The following is a description of a gene set: studied in species Homo sapiens The chemical reactions and pathways involving isoprenoid compounds, isoprene (2-methylbuta-1,3-diene) or compounds containing or derived from linked isoprene (3-methyl-2-butenylene) residues. Human Gene Set: GOBP_ISOPRENOID_METABOLIC_PROCESS, and this is the list of marker genes: ALDH1A3, RDH8, PMVK, LPL, SCPEP1, SDR16C5, SRD5A1, AKR1C1, DGAT1, ABCA4, ALDH1A2, ALDH3A2, AKR1C3, HTRA2, CYP2C18, FDPS, DPM1, DHRS4L2, DHRSX (NCBI Gene Id 207063), PNLIP, PRMT3, AKR1B10, CYP2E1, LIPE, CRPPA, DGAT2, LIPA, CYP2D6, LRP8, CYP2W1, LRP1 (LDL receptor related protein 1), PDSS2, AWAT2, ADH4, HSD17B6, CYP26B1, PNPLA2, LSS (lanosterol synthase), CEL, FDFT1, IDI2, IDI1, DHDDS (NCBI Gene Id 79947), AKR1C4, CYP2C19, ADH1A, CRH, CYP1B1, CYP3A4, ADH1C, CYP27C1, PNPLA4, RPE65, UGT1A8, PLPP6, RARRES2, SRD5A3, ALDH1A1, HMGCR, UGT1A7, DHRS9, RLBP1, LRAT (NCBI Gene Id 9227), CRABP2, DHRS3, ADH5, MVD (mevalonate diphosphate decarboxylase), LDLR, AKR1B15, RDH11, DHRS4L1, RBP4, UGT1A1, PHYH, RDH10, LRP2, RBP1, BCO2, NPC2, DPM3, AKR1B1, GGPS1 (NCBI Gene Id 9453), PDSS1, CYP1A1, PLB1, COQ2, DHRS7, RETSAT, CYP2S1 (cytochrome P450 family 2 subfamily S member 1), MVK, CYP2C9, SDR9C7, CYP4V2, UGT1A3, CYP26C1, RBP2, TTR, CLPS, RDH13, CYP1A2, HMGCS2, RDH5, DOLK, CYP2C8, ADH6, NUS1, DPM2, RDH16, RDH12, UGT1A9, PECR, ALDH8A1, CYP3A7, ADH1B, RBP3, BCO1, CYP3A5, RDH14, CYP26A1, HMGCS1, DHRS4, ADH7